The following is a description of a gene set: mouse primary BMDCs were stimulated with tlr ligands and gene expression changes were profiled on Affymetrix arrays Genes down-regulated in comparison of dendritic cells (DC) stimulated with LPS (TLR4 agonist) at 1 h versus DC cells stimulated with poly(I:C) (TLR3 agonist) at 1 h. studied in species Homo sapiens Human Gene Set: GSE17721_LPS_VS_POLYIC_1H_BMDC_DN from publication Amit I, Garber M, Chevrier N, Leite AP, Donner Y, Eisenhaure T, Guttman M, Grenier JK, Li W, Zuk O, Schubert LA, Birditt B, Shay T, Goren A, Zhang X, Smith Z, Deering R, McDonald RC, Cabili M, Bernstein BE, Rinn JL, Meissner A, Root DE, Hacohen N, Regev A (PMID 19729616), and this is the list of marker genes: URI1, RRP1B, LUC7L3, ZC3H7A, SELL (NCBI Gene Id 6402), EPHA5, HNRNPA3 (NCBI Gene Id 220988), AP3B1, ABCC1, IRX3, PKIB, FOXB1 (forkhead box B1), CERT1, MALAT1, MYORG, VPS9D1, KLF15, MNS1, PHF2, SORT1, BMP6, C3, CLP1, NECAP2, GRIA3, ZNF746, ZNF841, KDM3B, UBN1, TCF3, ALG2, DAZAP2, RIOX1, CD300LF, TAF8, PPIL4, ATP13A2, NUDT16, LUC7L, DPM2, UNC45A, OGA, CRABP2, DDX39B, SPINT2, FIZ1, PCYOX1, TRIM8, PREB, HPS3, EIF5B, RNF185, TMEM150A, TMEM140, GSTT1, C1QBP (complement C1q binding protein), GADD45G, PIK3CG, CDC25A, ANXA11, UCKL1 (NCBI Gene Id 54963), CLASRP, ADNP, SCAF11, CPA3, LUZP1, NR0B1, PIGT, UBTF, SH3BGRL3, SERPINC1, TSTD1, CALHM2, EDRF1, DHX57, ERAS, COL4A4, TNC, GCNT2, BAG2, GGA2, TP53INP1, MX2, RSRP1, ARRDC1, SREK1, CELSR3 (cadherin EGF LAG seven-pass G-type receptor 3), PTBP3, AQR, ENTPD4, MAD2L1BP, BFAR, HP1BP3 (NCBI Gene Id 50809), OAZ2, OPRL1, GPALPP1, EEF1B2, CALB1, CES3 (carboxylesterase 3), DNAJB8, PLEKHN1, REC8, METTL25B, PTP4A2, CREBZF, RNPEPL1, BIRC2, PSMB9, TRIM7, XRN1, GABRA1, WNT11 (NCBI Gene Id 7481), FAM8A1, SNAPC2, RHOQ, OPHN1, CPSF4 (NCBI Gene Id 10898), IMPACT, MEOX1, CHD7, HINFP, FKBPL, SLC2A3, SMARCA2, CRKL, CKAP4, TAOK1, SLFN12, CTU1, SLC16A6, PARP3, BMS1, ADIPOR2, MPZL2, VAMP1, LMNB1, OSBP, FAU, USP43, KDELR1, ORAI1, GPAM, LRRK1, PFKP, PITPNM1, SACS, ZNF688, NOPCHAP1, FBXL12, GDA, SENP1, SOX4, SMG5, PCGF2, ANGEL2, DIAPH2, CANT1 (NCBI Gene Id 619513), SAPCD1, HSD17B11, MAGI2, OGFOD2, IFRD2, TMEM87A, SIGIRR, KLHDC3, CDC37L1, REXO4, ARMC10, ADD3, PCBD1, POLG, CASC3, CTCF, SPIB, RNF34, SNTB1, H3C4, LTO1, ARHGEF40, G3BP1, CA2, ACVR1B, SOCS1, TRIP13, HDAC2, SPEN, EXOSC8, TMEM47, CLU, GLRA4, CAPN6, ELK4, CACNA1S, ICE2, PRKAG1, E4F1, PDCD4, DNAJC10, YWHAH